The following is a description of a gene set: studied in species Homo sapiens Human Gene Set: GOCC_MICROBODY_MEMBRANE The lipid bilayer surrounding a microbody., and this is the list of marker genes: PEX1, ABCD1, PJVK, ACOX1, MGST1, ALDH3A2, PEX16, TMEM135, PXMP2, IMPDH2, PEX10, ACBD5, AGPS, PEX3, FAR2, PXMP4 (peroxisomal membrane protein 4), PEX6, PEX11G, CNOT1, TTC1, PEX19, ABCD3, PECR, PEX11A, PEX5L, ABCD2, CAT, PEX5, PEX26, NBR1, ABCD4, FNDC5, SLC27A2, HMGCR, RAB8B, SYT7, PEX12, USP30, PEX7, PEX14, ATAD1, DHRS4, DHRS7B, MPV17L, MAVS, PEX2, DECR2, ACSL4, FIS1, MPV17, GNPAT (glyceronephosphate O-acyltransferase), SLC25A17 (solute carrier family 25 member 17), HSD17B4, ACSL1, MAP2K2, PEX13, FAR1 (NCBI Gene Id 84188), ACSL3, ACSL6, PEX11B, PLAAT3, PNPLA8, TMEM35A, TRIM37, GDAP1